Given this list of marker genes FOS, LIPG, KATNA1, TMEM229B, JUNB, UACA, GRK3, FAS, IL10, EZR, MAP3K8, MALT1, RIPK2, HOMER1, ASB13, TPST1, ARHGEF3, PLOD2, PLEKHA4, ZFP36, BCL3, ZBTB32, SEC24B, NLRC5, ZC3H7A, ETNK1, PLA2G4A, PLAGL1, WDR43, ZNF800, ST6GALNAC4, CMTM6, MITD1, HOPX, BFAR, MYO10, MTMR7, DGKH, SPHK1, TNFSF4, PFKFB3, LRCH1, MPP7, TIAM1, LCK, GCA, MED13L, LUZP1, PARP8, SLC4A7, SPRED1, RGS16, FLNB, CD83, MAPKBP1, IL13RA1, DCP1A, TASOR2, MIR155HG, CSRNP1, PCGF5, SLC2A6, FAM241A, JARID2, TMEM50B, NFKBIZ, REL, EXT1, RHBDF2, GBP6, RAI14 (retinoic acid induced 14), ERRFI1, DUSP5, NOD1, ADAP2, GPSM2, LRRFIP1, HIVEP2, CHD1, PTPRD, FZD1, CTSC, USP12, MCF2L, DENND1B, TLR3, RIN2, AIM2 (absent in melanoma 2), INPP1, BATF2, MFSD6L, ZUP1, GADD45G, SLC44A1, ITGB8, MX1, HBEGF (heparin binding EGF like growth factor), CGAS, PDZK1IP1 (NCBI Gene Id 10158), MT1X, TNFSF8, MINPP1, VCPIP1 (valosin containing protein interacting protein 1), DAAM1, LNPK, RBL1, SLC16A1, SPSB1, RFFL, TRAF3IP2, IL12B, ENDOD1, GOLGA3, NECTIN2, ICOSLG, GNA15, NOCT, SAMHD1, NOTCH1, ADGRL2, NECTIN4, NFIX, SNN, ETV6, F11R, FZD5, SLC30A4, PPFIBP1, CD69, COL18A1, SELP, DUSP2, VEZT, WHAMM (WASP homolog associated with actin, golgi membranes and microtubules), LANCL2, ZDHHC21, IL15, TRIM21, STAT3, AFF1, DENND6B, TANC1, NIBAN1, IL15RA, HDC, TBC1D1, TAL1, PLEKHA2, COL27A1, PTX3, CITED2, PLAUR, DLL1, MT1F, TMEM171, VCAN, PRR5L, FAM32A, TNFSF9, TMTC2, TNC, ZNF281, POU3F1, APAF1, TMA16, PTGS2, KLF7, TRAF1, KPNA3, AGRN, SEPTIN11, IGSF9, CDKN1A, STX6, HHEX, FANCC, FKBP5, CREB5, GLIPR2, TUBB6, LCP2, VCAM1, GBP4, TPBG, ARF4, IL18, ODC1, SHISA3, DUSP14, PDE4B, SERTAD3, SEMA4C, CAMK2D (calcium/calmodulin dependent protein kinase II delta), KAT6A, RCAN1, LHX2, TENT4A, RANBP2, PPA1, OGFRL1, RAC3, SLC25A22, CEMIP2, PPM1K, GYPC, TPM4, SLFN5, TIPARP, CAV1, DAXX, TRA2A, SLFN12, SP110, MTFR2, CTNNAL1, UPP1, TCF4, OLR1, KREMEN1, PTPRJ, NCOA7, SGK3, AKT3, ZBTB8A, JAK2, ETV3, ARL4A, IL4I1, EDN1, RIGI, IFI16, NUP58, MMP13, FOXP1, SERTAD1, CH25H, CENPJ, AIDA, TNFAIP3, SPATA13, RILPL1, GJA1, FMNL2 (NCBI Gene Id 114793, formin like 2), NFKB1, N4BP1, MYADM, CD86, MIER3, EXOC3L4, PHIP, SOCS1, ARID5A, CXCL11, GK, PLEKHF2, STAT5A, CACNB3 (calcium voltage-gated channel auxiliary subunit beta 3), HMGN3, PPP1R15B, SCHIP1, TOR1AIP2 (torsin 1A interacting protein 2), ARHGAP26, F2R, GRAMD1A, FMR1, TNFRSF12A, NFKBID, ZYX, SLC39A14, CNN3, ATP9B, SOCS3, BLTP1, IL1B, ALCAM, MAFK, TJP2, OTUD1, HSPA1B, MAP2K4 (NCBI Gene Id 6416), JDP2, ATP11B, TNFSF10, CCND2, ENTR1, NEK6, PML, LPAR1, NOC4L, ILRUN, GNG4, ZEB1, MTMR14, RHOH, GCNT2, S100A10, PRKX, TET2, FSCN1, PDSS1, TMEM243, GDA, MACIR, CEBPD, PIM1, SRC, FRMD4A, RAP2C, SLCO3A1, CP, KTN1, LMNA, PRPF4, GSPT1, USP42 (ubiquitin specific peptidase 42), CHD7, MARCHF5, SERPINA3, DUSP16 (NCBI Gene Id 80824), DRAM1, SFPQ, TLE3, SETDB2, PRPF38A, PMEPA1, RND3, SYNE3, ENG, SHFL, PARP14, WDR59, TMEM219, ADGRG6, NAMPT, RMDN3, CASP12, IRF2, PDLIM5, IQSEC2, PHLDB1, KHDRBS1, SLC12A4, BCL9, RNF125 (ring finger protein 125), TRIM26, NSD3, XRN1, DNAJA2, DCP2, SLC45A3, AEBP2, UBASH3B, TAB2, XKR8, IRGM, SLC30A1, FEZ2, NR3C1, SNX10, SERPINE1, ITGAV, FILIP1L, FNBP4, TUT7, TMEM30A, GPR84, ANGPT1, CD40, TLK2, NFXL1, CDS1, FOXP4, RND1, IFIH1, SLFN13, IL6, MGAT4A, AREL1, IKZF1, ARMC8 (armadillo repeat containing 8), ZNRF3, IL4R, CHST11, CSF1 (NCBI Gene Id 1435), NOS2, SRSF3 (NCBI Gene Id 6428), TAGAP, MTUS1, CCL22, SMIM36, ATP10A, NFIL3, GNB4 (G protein subunit beta 4), TRIP10, MOB3B, CASP7, ITPKB, PHC2, ADAMTS4, DGKA, IL33, CA2, SDC4, MXD1, SOCS7, ABTB2, RCN1, PIK3R6 (NCBI Gene Id 146850), SOCS2, B4GALT5, SECTM1, TMCO3, here is a description of the gene set: studied in species Mus musculus Human Gene Set: FOSTER_TOLERANT_MACROPHAGE_DN Toll-like receptors (TLRs) induce a multi-component inflammatory response that must be tightly regulated to avoid tissue damage. Most known regulatory mechanisms target TLR signalling pathways and thus broadly inhibit multiple aspects of the inflammatory response. Given the functional diversity of TLR-induced genes, we proposed that additional, gene-specific regulatory mechanisms exist to allow individual aspects of the TLR-induced response to be differentially regulated. Using an in vitro system of lipopolysaccharide tolerance in murine macrophages, we show that TLR-induced genes fall into two categories on the basis of their functions and regulatory requirements. We demonstrate that representatives from the two classes acquire distinct patterns of TLR-induced chromatin modifications. These gene-specific chromatin modifications are associated with transient silencing of one class of genes, which includes pro-inflammatory mediators, and priming of the second class, which includes antimicrobial effectors. These findings illustrate an adaptive response in macrophages and reveal component-specific regulation of inflammation. Class NT (non-tolerizeable) genes: induced during the first LPS stimulation and induced at equal or greater degree in tolerant macrophages. from publication Foster SL, Hargreaves DC, Medzhitov R (PMID 17538624)